Given this list of marker genes CRB1, VPS54, LARGE1, DSCAM, ATRX, NKX2-3, here is a description of the gene set: The process, occurring after animal embryonic development, by which anatomical structures are generated and organized. Human Gene Set: GOBP_POST_EMBRYONIC_ANIMAL_MORPHOGENESIS studied in species Homo sapiens